The following is a description of a gene set: Age of death The age group when the cessation of life happens. studied in species Homo sapiens Human Gene Set: HP_AGE_OF_DEATH, and this is the list of marker genes: SUOX, POLR3A, CTSD, CNTN1, ALB (NCBI Gene Id 29004), SLC26A2, LAMA3, FLNB, COX16, DNM2, CEP55, TPI1, FKBP6 (NCBI Gene Id 8468), ABCA12, DPM2, PAM16, FCGR3B, DNM1L, COG7, DLD, CLCN3, PIGB, MSH2, FAM111A, HYLS1, GPC3, NFIX, HBB, TSEN2, SNAP29, ATP1A2, RET, PHGDH, IDUA, FKRP, PMS2, NFU1, DNAJC30, NUP214, JAM3, REV3L, ATP5F1A, MFF, THSD1, PLVAP, LIMK1, DPH1, DLK1, NPHP3, VPS33B, RNU4ATAC, TBXT, RARB, ALPL, GBA1, FCHO1, NEB, RBM10, REC114, PEX1, DONSON, PMM2, TOR1A, MRPL3, ALG1, EPCAM, MYL2 (NCBI Gene Id 4633), WASHC5, RHD, MPI (mannose phosphate isomerase), SLC33A1 (NCBI Gene Id 9197), SFTPB, FOXF1, FRAS1 (Fraser extracellular matrix complex subunit 1), TGFBR2, CDC40, TMEM260, GRIP1, LIFR (NCBI Gene Id 3977), OSTM1, MGP, SERPINH1 (NCBI Gene Id 89588), HDAC6, LIPT1, SLC17A5, SNRPB, INTU, ITGB4, DSP, TK2, RYR1, RRAGC, ARX, ETHE1, POMT2, PEX12 (peroxisomal biogenesis factor 12), NDUFAF4, NDUFV1, PPIL1, KRAS (KRAS proto-oncogene, GTPase), CPT2, PQBP1, EPG5, CAD, MYH7, ROR2, NDUFA2, SLC35D1 (NCBI Gene Id 23169), ETFA, GFM2, VPS35L, PEX14, COASY, RAB27A, MFSD2A, HTRA2, POR (cytochrome p450 oxidoreductase), MYF6, LAT, HADHB, NADK2, AARS2, ERCC4, SLC25A4, HOXA13, PSAT1, ASCL1, SMN1, NUP88, PITX1, PLXND1, ACTA1, FHL1, PTF1A, KARS1, SMO, WRN, RHAG, CALCRL, ETFB, CRLS1, ORC1, GNPTAB, ADCY5, PTPRC, IKBKB, SURF1, CLN8, GLI3 (GLI family zinc finger 3), OGDH, CLCF1, DHCR7, LMNA, GPR161, EIF4H, VPS4A (vacuolar protein sorting 4 homolog A), POT1, SERPINE1, ACTN2, GTF2IRD1, WDR11, NDUFAF3, GDF5 (growth differentiation factor 5), CCDC22, TNNI3, NDUFS6, JAK2, MRPL44, MYLK, DLL3, ATRX, SEC31A, PLIN1, MBTPS2, RHCE, ANTXR2, MALT1, RTL1, IFT56, SLC25A22, C18orf32, SATB1, TTC7A, VPS50, TSEN54, PHOX2B, COX10, WT1, ERCC5, STRA6, TRMT10C, EDNRB, PIP5K1C, FGB, LRPPRC, ABCB11, RNASEH2A, FGA, CENPF, VPS37D, COX11, PEX3, FLI1, NSDHL, RBM8A, BIN1, PIK3CA, LMOD3, THPO, STAT2, GATC, PEX13, ATAD3A, GET3, ROBO1, GAD1, FLNA, LBR, COX5A, AP1S1, NRAS, UBR1, COX8A, RARS2, SUCLG1, NAXD, MADD, PLEC, CDON, HESX1, ACTL6B, MEG3, FXR1, NDUFB10, QRSL1, TPP2, EXOC8, BOLA3, CD96, EXTL3, ACADVL, TMEM70 (transmembrane protein 70), AIMP2, FGFR3, RBMX, MSH6, PMS1, KRT5, ZNFX1, MDFIC, EFL1, SMOC1, PPCS, ACOX1, MPDU1, MESP2, FANCB, CLIP2, PSAP, MOCS2, TFAM, TARS2, ITGA6, LAMC2, MYH6, MRPS16, SOST, FTO, TYMP, ZIC3, PEX6, NHLRC2, ARHGEF9, IL6ST (interleukin 6 cytokine family signal transducer), SERPINC1, ATP5MK, MTX2, ENG, PEX2, ABAT, AIMP1, C2orf69, ORAI1, DPYSL5, RPL3L, RMND1, CEP120, ADCY6 (adenylate cyclase 6), COG6, NAXE, ABCA3, PEX10, GTF2IRD2, ALG8, TRIP11, MLH1, TMEM270, SDHD, DTYMK, COL2A1, PRPS1, LIPA, PEX5, CDK5, NOP10, METTL27, VPS33A, ATP7A, FAM20C, SCO2, ASXL3, RAD51C, NPC2, PIGY, SLC25A24, ECHS1, CNTNAP1, FREM2, PEX26, HEXB, EXOSC8, PEX11B, DKC1, OCRL, NDUFS4, NADSYN1, PEX19, PEX16, MT-TN (NCBI Gene Id 4570), CRIPT, LHX4, NDUFB8, GLDC, SLC52A3, ALG11, MRPS22, GPC4, NEK8, GLE1, STX3, PET100, PLS3, STT3B (STT3 oligosaccharyltransferase complex catalytic subunit B), LGI4, ERCC6, LAMB2, STX1A, MRM2, GRM7, ACAD9, JPH2, NDUFB11, NDUFS7, ACTB, BRAT1, OAS1, LMOD1, MYO5B, ERCC2, ALG14, PLCB3, GLUL, ELN, FADD, ERCC1, APP, ITPA, HSPG2 (heparan sulfate proteoglycan 2), RINT1, CRPPA, PROKR2, SMARCD2, TUFM, MPL, ACTG2, LAMB3, TSPYL1, AFF3, RNASEH2C, NCF1, CD3G, ESCO2, COL11A1, TIMMDC1 (translocase of inner mitochondrial membrane domain containing 1), GPHN, FARS2, CRLF1, NSD2, MYH11, DCX, KLHL40, TBL2, ELAC2, MUSK, POLG, PPFIBP1, SLC25A46, CST3, SLC25A19, ATP6AP1, EMG1, RFC2, SCN1B, LMOD2, SCYL2, BAZ1B, NLRP7, CAMSAP1, LTBP4, LYRM7 (NCBI Gene Id 90624), EFEMP2, POLR3B, LTC4S, ETFDH, GFAP, CRYAB, ELOVL4, DPH5, PKHD1, DYNLT2B, PTH1R, BMPR1B, TRMU, PIGA, LIPT2, PSMB8, DOLK, SCN4A, VIPAS39, ATPAF2 (ATP synthase mitochondrial F1 complex assembly factor 2), HMGCL, NFS1, SIK1, NDUFV2, MRPS34, MTMR14, KIF20A, BUD23, NXN, CRTAP, NR1H4, PAICS, NSF, ZMPSTE24, CNOT1, MYL1, ATG7, GTF2I, FGG, TSFM, BCS1L, TNFRSF11A, GLB1, SMPD4